Given this list of marker genes GANC, HHEX, MPHOSPH9, ANKRD54, PGRMC2, RHBDF1, AFG2A, SATB1, EDNRB, DENND4A, PPP6R3, WDFY3, TUT7, OGG1, U2AF2, CCN4, SELENOH, MSANTD4, PLEKHA4, DENR, MEX3C, DSTN, GPATCH2L, DCX, DGKK, RPS6KA3, MARCKSL1, ANAPC4, RIMKLB, PCDH10, ATOH8, ERP27, GLCCI1, LCE1B, SLC30A7, ZNF197, IBTK, CNOT6L, DDX3Y, SLC2A2, NANP, SDC3, CLN5 (CLN5 intracellular trafficking protein), AFF1, AHNAK, JAM3, PLK2, FBN2, RANBP10, DDB2, C18orf54, NKX2-2, CNOT1, CPSF6, RAPGEF5, SCN2A, PIP5K1C, B3GNT2, CAMK1D, TMEM230, CRIPT, CPD, MARCHF6, FGF1, ZBTB20, MAP4K3, LRRC2, GRIN2A, MDC1, APBB2, ZFTA, SERPINB9, CSDE1, COL16A1, ATP11C, LRP6, NECTIN1, PCDH11X, here is a description of the gene set: Human Gene Set: MIR3187_3P species: Homo sapiens Genes predicted to be targets of miRBase v22 microRNA hsa-miR-3187-3p in miRDB v6.0 with MirTarget v4 prediction scores > 80 (high confidence targets). from publication Chen Y, Wang X (PMID 31504780)